The following is a description of a gene set: Mouse Gene Set: GOBP_POSITIVE_REGULATION_OF_MACROPHAGE_MIGRATION studied in species Mus musculus Any process that activates or increases the frequency, rate or extent of macrophage migration., and this is the list of marker genes: Csf1, Ccl2, Csf1r, Cxcl17, Rtn4, P2rx4, Trem1, Rarres2, Tnfsf18, Cx3cr1, Ccl5, Il34, Slamf1, Thbs1, Akirin1, Ccl21a, P2ry12, Trpv4, Ccr7, Mapk1, Mstn, C5ar1, Cx3cl1, Mapk3, Mdk, Cmklr1, Trem2, Ptk2, C3ar1, Ptprj, Mmp14